Given this list of marker genes ZDHHC2, FRRS1L, SLC7A11, DLG4, APOE, SHISA6, SHISA7, SSH1, CHRDL1, NLGN1, SHANK3, here is a description of the gene set: The glutamate receptor clustering process in which alpha-amino-3-hydroxy-5-methyl-4-isoxazole propionate (AMPA) receptors are localized to distinct domains in the cell membrane. Human Gene Set: GOBP_AMPA_GLUTAMATE_RECEPTOR_CLUSTERING studied in species Homo sapiens